The following is a description of a gene set: Human Gene Set: GOBP_REGULATION_OF_DENDRITE_DEVELOPMENT studied in species Homo sapiens Any process that modulates the frequency, rate or extent of dendrite development., and this is the list of marker genes: FZD4, TLX2, SKOR2, SLC30A1, ADGRB3, PQBP1, BCL11A, ABL1, NUMBL, EPHA4, CUX1, CRKL, LRP8, SS18L1, CAMK1D, YWHAH (NCBI Gene Id 7533), FBXW8, CARM1, TBC1D24, RAB21, SEMA4D, ARF6, NR2E1, MARK1, PARP6, DPYSL5, GORASP1, NFATC4, CDKL5, GPRASP3, PREX1, DGKG, OBSL1, STK11, KHDC3L, HECW1, TRPC6, LZTS1, CAMSAP2, RELN, PACSIN1, KIAA0319, CAMK2B, DBN1, NEUROG3, EEF2K, CDKL3, NEDD4 (NCBI Gene Id 4734), CUX2, GSK3B, SDC2, ARMCX5-GPRASP2, ANAPC2, PAFAH1B1, EPHB2, FAT3, BAIAP2, TNIK, RAPGEF2, ZNF296, TMEM106B, CSMD3, SARM1, CHRNB2, IL1RAPL1, CHRNA3, CDC20, PPP3CA, RAB17, SEZ6, RAP2A (RAP2A, member of RAS oncogene family), STAU2, BMP7, CUL7, VLDLR, CAPRIN1, PTN, PTPRD, BMP5 (NCBI Gene Id 653), RTN4IP1, MGARP, HDAC6, EZH2, CRK, MFSD2A, KNDC1, TRPC5, COBL, NSMF, ZDHHC15, DAB2IP, HECW2, DHX36, ALK, SMAD1, ANKRD27, NEDD4L, BMPR1A, CAPRIN2, ITPKA (inositol-trisphosphate 3-kinase A), DCC